The following is a description of a gene set: Genes up-regulated in HeLa cells (cervical carcinoma) upon knockdown of PHF8 by RNAi. Human Gene Set: FORTSCHEGGER_PHF8_TARGETS_UP Mutations in PHF8 are associated with X-linked mental retardation and cleft lip/cleft palate. PHF8 contains a plant homeodomain (PHD) in its N terminus and is a member of a family of JmjC domain-containing proteins. While PHDs can act as methyl lysine recognition motifs, JmjC domains can catalyze lysine demethylation. Here, we show that PHF8 is a histone demethylase that removes repressive histone H3 dimethyl lysine 9 marks. Our biochemical analysis revealed specific association of the PHF8 PHD with histone H3 trimethylated at lysine 4 (H3K4me3). Chromatin immunoprecipitation followed by high-throughput sequencing indicated that PHF8 is enriched at the transcription start sites of many active or poised genes, mirroring the presence of RNA polymerase II (RNAPII) and of H3K4me3-bearing nucleosomes. We show that PHF8 can act as a transcriptional coactivator and that its activation function largely depends on binding of the PHD to H3K4me3. Furthermore, we present evidence for direct interaction of PHF8 with the C-terminal domain of RNAPII. Importantly, a PHF8 disease mutant was defective in demethylation and in coactivation. This is the first demonstration of a chromatin-modifying enzyme that is globally recruited to promoters through its association with H3K4me3 and RNAPII. studied in species Homo sapiens from publication Fortschegger K, de Graaf P, Outchkourov NS, van Schaik FM, Timmers HT, Shiekhattar R (PMID 20421419), and this is the list of marker genes: CDC37L1 (cell division cycle 37 like 1, HSP90 cochaperone), SERP1, VLDLR, LMO4, STEAP3, FOXN3-AS1, TUSC2, FZD7, CENPV, FNBP1L, DHRS3, DPCD, RBKS, ASNS, CHAC1, LINC00467, CRB1, MIR99AHG, ZNF267, PRG4, RELL1, A2M, SLC7A11 (solute carrier family 7 member 11), BCL2L11, ECM2, SGPL1, SUZ12, PDGFC (platelet derived growth factor C), FUBP1, NEK4, ALDH1A3, HTRA3, PDHX, MBTD1, FAM90A9, XIAP, KLF9, CCNYL1, PTPN2, RIDA, RBM33, SPA17, DUSP16, CDH24, MESD, ALDH1L2, CLN3, DCAF17, HINT3, MND1, RASSF9, NKAIN1, TSPAN3, IQCK, ANKRD46, ECE1, FZD10, TRMT10A, TCP10L, DUSP2, SYNCRIP, STX6, BNIP2, KLHL7, PDE1A, ENAH, CBX5, FBXW10, UCP3, GCLC, TIPIN, UGT2B10, SESN2, SPACA9, BMP6, PDK4, GPT2, DCBLD1, JMY, NUPR1, JAG2, VEGFA, CCNY, FZD5, ITPR1, BMP2, BET1, VAMP1, MTLN, FAM86C1P, SLF1, YES1, DNAJB4, OSCP1, ACVR2B, PTP4A1, VTI1B, IGF1R, IQCG, DCAF4, RIMKLB, GABPB1, ID1, TMEM116, TBC1D31, SINHCAF, ZNF280C, NCOA7, ZP3, RAB10, MTHFD2, FBXW7, EFNA1, SORBS2, AKR1C1, KCNK3, PTGES2, MOK, ZNF76, HERPUD1 (homocysteine inducible ER protein with ubiquitin like domain 1), CCN2, FAM86B1 (family with sequence similarity 86 member B1), GID8, URI1, INHBE, GRB10, HBP1, GLP2R, RCOR3, SERF1A, NPTX1, MAP2, PIAS2, PYCR1, MOCS2, KPNB1, LCOR, C6orf62, FAM120C, TNPO1, NDC1, RASD1, TGFBR2, WWP1, NKAPD1 (NKAP domain containing 1), PIERCE1, GSK3B, FAM217B, SEC62, NQO1, MIR17HG (miR-17-92a-1 cluster host gene), RASA4, LYG1, CALU, LYRM7, HLX, KDM7A, STOX2, EIF2AK4, TNFRSF11B, JPT1, SETD4, NR4A1, NQO2 (N-ribosyldihydronicotinamide:quinone dehydrogenase 2), OTULINL, NR2F1, INSR, GKAP1, LRP8, CBX8, IVNS1ABP, XYLT2, MCM3AP-AS1, PABPC4, KLHL15, CTAG1A, JADE1, FKBP1A, NSRP1 (nuclear speckle splicing regulatory protein 1), TPCN1, KLRG1, NMNAT1, DDAH1, ZNF721, HEY1, MRPL42, RPIA, PHGDH, TFPI2, PCSK1, MAP7, ARL6IP1, DDX3X, ARHGAP28, SSU72, RIMS4, SCD, HMGB3P1, MAT2B, KRCC1, ZG16B, SLC16A1 (NCBI Gene Id 6566), PUDP, SMC5, TRAPPC3L, KRTDAP, TXNIP, INSL4, PTPRJ, NLN, PCK2, CALML4, GPR180, RAB8A, YKT6, DPY19L4, RNF141 (NCBI Gene Id 50862), GABPB2, LZTFL1, CDC26, MAN1A1, DDIT4, ASMTL, NFYB, ATF4P3, ACP3, NEK10, SYT15, CMTM7, TOP2B, GRAMD1B, EIF5, LIN9, MRRF, HMGB2, SET, TBC1D4, DYNLT2B, VAV3, PABPN1, PPDPFL, CHML, ATPSCKMT (NCBI Gene Id 134145), CNOT6, E2F5, PDE4D, BID, CCDC77, LINC00689, IL20RB, SLC16A6, ADAMTS1, TSPAN13, FAM90A10 (NCBI Gene Id 441328), NR0B1, CERK, TFPI, CTSC, RERG, MLXIPL, STC2, MCF2L (MCF.2 cell line derived transforming sequence like), SERF1B, MGAT5, ATF4, SLC2A3, TMEM79, BBOF1, SLC19A2, FBXW10B, RNLS, TMTC4, FAM171A1, FAM27B, CITED2, CCDC6, HMOX1, HOXA5